The following is a description of a gene set: studied in species Homo sapiens Human Gene Set: GOBP_SERINE_FAMILY_AMINO_ACID_METABOLIC_PROCESS The chemical reactions and pathways involving amino acids of the serine family, comprising cysteine, glycine, homoserine, selenocysteine and serine., and this is the list of marker genes: SERINC5, SCLY, SHMT1, MPST, PSAT1, ENSG00000274276, GGT1, RIDA, NDP, AGXT2 (NCBI Gene Id 64902), PHGDH, SEPHS2, GLDC, SDSL, CBS, SERINC3, MTHFD1, THNSL2, CDO1, GCSH, AGXT, SRR, BAAT, SDS, CTH, HAO1, PSPH, AMT, CSAD, SEPHS1, SHMT2, GLYAT